The following is a description of a gene set: Myelopathy is an descriptive term, referring to pathology leading to a neurologic deficit related to the spinal cord. The clinical diagnosis of myelopathy requires a detailed history and physical examination to define the clinical syndrome. Neuroimaging is indicated in most instances of new-onset myelopathy. It is indicated also when the worsening of a myelopathy is unexplained. Human Gene Set: HP_MYELOPATHY species: Homo sapiens Myelopathy, and this is the list of marker genes: COL2A1, EXT1, GNPTAB, GALNS, CYP27A1, RASA1, EXT2, NF2, NMNAT1, ARSB, BTD, NAXE, GLB1 (galactosidase beta 1), ABCD1, DKK1 (dickkopf WNT signaling pathway inhibitor 1)